The following is a description of a gene set: Mouse Gene Set: WP_EICOSANOID_METABOLISM_VIA_CYTOCHROME_P450_MONOOXYGENASES studied in species Mus musculus Eicosanoid metabolism via cytochrome P450 monooxygenases, and this is the list of marker genes: Cyp2c54, Cyp4f14, Cyp2c23, Cyp2c29, Cyp4a12a, Ppara, Cyp2c38, Cyp4f18, Cyp2j5, Cyp2c37, Cyp2c40, Cyp4a12b, Cyp4a10, Ephx2, Cyp2c55, Cyp2c39 (NCBI Gene Id 13098)